The following is a description of a gene set: Human Gene Set: HP_MACROTHROMBOCYTOPENIA studied in species Homo sapiens Macrothrombocytopenia, and this is the list of marker genes: ITGA2B, TUBB1, TUBA8, ABCG5, ABCG8, GALE (NCBI Gene Id 2582), GP9, GP1BB, TPM4, GATA1, GP1BA, GFI1B, MYH9, DIAPH1, SLC35A1, PRKACG